Given this list of marker genes CRKL, PIK3R1, NCK2, SRC, PIK3R2, STAT5B, PDGFA, RAPGEF1, PDGFRB, GRB7, CRK, HRAS, PDGFB, PTPN11, STAT6, STAT3, BCAR1, PIK3CA, KRAS, PIK3CB, GRB2 (growth factor receptor bound protein 2), PDGFRA, NCK1, SOS1, PLCG1, NRAS, RASA1, STAT1, STAT5A, here is a description of the gene set: studied in species Homo sapiens Downstream signal transduction Human Gene Set: REACTOME_DOWNSTREAM_SIGNAL_TRANSDUCTION